Given this list of marker genes KCNH1, ATP6V1B2, COG4, ZMPSTE24 (NCBI Gene Id 10269), LMNA, KCNN3, here is a description of the gene set: Human Gene Set: HP_OVERTUBULATED_LONG_BONES Overconstriction, or narrowness of the diaphysis and metaphysis of long bones. Overtubulated long bones species: Homo sapiens